Given this list of marker genes F2RL1, TH, ID2 (inhibitor of DNA binding 2), SCNN1A, GRB7, GAS2L1, MAL, ADGRE5 (NCBI Gene Id 976), TRIO, RGS3, CHKA, INHBB, FGF9, CEBPA, SH3BP2, CLDN4, UMOD, SMAD6, NKX2-1, RBPMS, MIR9-1HG, TSC22D3, GGT2P, RHOB, TM4SF5, ERBB3, TOB1 (transducer of ERBB2, 1), ELF3, GADD45A, SMAD7, MTMR11, PLAU, HES1, FZD7 (frizzled class receptor 7), DUSP10, BCAR3, DYRK2, CCN2, ROR1, KRTAP5-9, TFAP2C, CCN1, ARHGAP29, STC2, ARL4C, here is a description of the gene set: Genes down-regulated in H358 cells (lung cancer) by inducible expression of CEBPA off plasmid vector. We showed previously that CCAAT/enhancer binding protein alpha (C/EBP alpha), a tissue-specific transcription factor, is a candidate tumor suppressor in lung cancer. In the present study, we have performed a transcriptional profiling study of C/EBP alpha target genes using an inducible cell line system. This study led to the identification of hepatocyte nuclear factor 3beta (HNF3 beta), a transcription factor known to play a role in airway differentiation, as a downstream target of C/EBP alpha. We found down-regulation of HNF3 beta expression in a large proportion of lung cancer cell lines examined and identified two novel mutants of HNF3 beta, as well as hypermethylation of the HNF3 beta promoter. We also developed a tetracycline-inducible cell line model to study the cellular consequences of HNF3 beta expression. Conditional expression of HNF3 beta led to significant growth reduction, proliferation arrest, apoptosis, and loss of clonogenic ability, suggesting additionally that HNF3 beta is a novel tumor suppressor in lung cancer. This is the first study to show genetic abnormalities of lung-specific differentiation pathways in the development of lung cancer. studied in species Homo sapiens from publication Halmos B, Bassères DS, Monti S, D'Aló F, Dayaram T, Ferenczi K, Wouters BJ, Huettner CS, Golub TR, Tenen DG (PMID 15205324) Human Gene Set: HALMOS_CEBPA_TARGETS_DN